Given this list of marker genes PTPRJ, SHOX2, TNFRSF1B, BAZ2B, APPL1, SLAMF8, TSPEAR, DGKI, TRIM47, YY1AP1, TOP1, HTR3B, SP6, SLC6A12, S1PR2, ILK, C1QL1, XPO6, UBE2D3, MMP9, CADM1, VEZF1, UACA (NCBI Gene Id 55075), FUT7, RHOG, BMP2K, RBMS1, IL27, IL13, FAM117A, SLC44A1, SH2B3, BATF, CD69, MTMR14, CDC42SE1, GNB1, KRTAP13-1, PFN1, UBE2I, TGIF1, DDR1, FGF17, SOCS2, IL2RA, CLCN1, BDNF, EHF, SIRT2, ARHGEF2, NFKBIA, MAML2, SMG7, ARHGAP8, ZNF800, PHOX2B, NEK8, TRAF4, REV3L, IL12A, TCEA2, PRDM12 (NCBI Gene Id 59335), NFKB2, ASH1L (ASH1 like histone lysine methyltransferase), TRIB2, PTHLH, MAP4K2, TASL, IL1RN, IFNL2, SMC6, DAP3, CHD6, MLLT11, CD40, UBD, TFE3, BCL6B, IER5, DUSP6, NFKBIB, EBF1, MIDEAS (mitotic deacetylase associated SANT domain protein), ZIC4, RFX5, FTHL17, CNTNAP1, LTB, ATP1B1, GABRB1, RFTN2, KRT23, BCL3, CXCR5 (C-X-C motif chemokine receptor 5), RASSF2, POU2F3, CD70, NTN1, FBXL12, CCR10, NPAS4, FGF1, ICAM1, INO80D, MAP3K11, MAG, ZNRF1, ANKHD1, LIX1L, NFAT5, COL27A1, EGF, PCBP4 (poly(rC) binding protein 4), ACAP3, VCAM1, MRPS6 (mitochondrial ribosomal protein S6), TP63, GPBP1, G3BP1, LUC7L3, UPF2, NR2F2, BIRC3, IL7, MOB3C, IFNL3 (NCBI Gene Id 282617), ADGRB2, RIN2, TNFSF18, SEMA3B, CTAGE4, NR3C1, SMOC1, ERN1, MSX1, KY, CREB1, PTMS, EIF5A, SMPD3, ACTN1, ENO3, GRK5, GADD45B, STON2, FAM241A, RELB, RAP2C, GREM1, RALGDS, HNF1A, PCSK2, KLK9, SIN3A (NCBI Gene Id 25942), HSP90B1, CHD4, MIR17HG, ZBTB9, ANKHD1-EIF4EBP3, MADCAM1, TNFSF15, ELMO1, AAMDC, ASCL3, PTGES, CCL5, CSF3, TNIP1, TMEM88, JAK3, RNF220, GEN1, STAT6, ORAI1, IL27RA, CTDSPL2, NOS1AP, GATA4, RNF43, AP1S2, WRAP53, TNIP3, CYLD, NDRG2, TP53, DUSP22, GRIN2D, NLK, TNFRSF9, RND1, IL6ST, HSD11B2, GDPD5, CEND1, PAPPA, RASGRP4, ARL5B (ADP ribosylation factor like GTPase 5B), ETV1 (ETS variant transcription factor 1), PPP1R13B, TBX20, GPHN, EDN2, PNKD, DCLK1, MITF, IFNB1, ALG6, TSLP, RBPJ, LTA, SOX5, AMOTL1, MSC, KCNT2, BMF, RSF1, RRP8, SNAP25, CCDC107, HIVEP1, PAN2, WNT10A, IL23A, UBE2H, IL4I1, SUN2, PRKCD, TJAP1 (NCBI Gene Id 93643), SEC61A1, CALCOCO1, ZBTB11, EP300, NFKBID, KANSL1L, GNG4, HSD3B7, EBI3, here is a description of the gene set: species: Homo sapiens Human Gene Set: NFKB_Q6_01 Genes having at least one occurrence of the motif NNNNKGGRAANTCCCN in the regions spanning 4 kb centered on their transcription starting sites. This matches the transcription factor binding site V$NFKB_Q6_01 (v7.4 TRANSFAC).